Given this list of marker genes PRMT1, PRMT3, PRMT8, PRMT7, PRMT6, here is a description of the gene set: Catalysis of the addition of a methyl group to either of the unmethylated terminal nitrogen atoms (also called omega nitrogen) in peptidyl-arginine to form an omega-N-G-monomethylated arginine residue. The reaction is S-adenosyl-L-methionine +-L-arginine = S-adenosyl-L-homocysteine +-Nomega-methyl-L-arginine. Human Gene Set: GOMF_PROTEIN_ARGININE_OMEGA_N_MONOMETHYLTRANSFERASE_ACTIVITY studied in species Homo sapiens